The following is a description of a gene set: species: Homo sapiens Catalysis of the reaction: S-adenosyl-L-methionine + (histone H4)-arginine (position 3) = S-adenosyl-L-homocysteine + (histone H4)-N-methyl-arginine (position 3). This reaction is the addition of a methyl group to the arginine residue at position 3 of histone H4, producing histone H4R3me. Human Gene Set: GOMF_HISTONE_H4R3_METHYLTRANSFERASE_ACTIVITY, and this is the list of marker genes: PRMT3, PRMT5, PRMT6, PRMT1, PRMT7